The following is a description of a gene set: from publication Amit I, Garber M, Chevrier N, Leite AP, Donner Y, Eisenhaure T, Guttman M, Grenier JK, Li W, Zuk O, Schubert LA, Birditt B, Shay T, Goren A, Zhang X, Smith Z, Deering R, McDonald RC, Cabili M, Bernstein BE, Rinn JL, Meissner A, Root DE, Hacohen N, Regev A (PMID 19729616) Human Gene Set: GSE17721_CTRL_VS_LPS_1H_BMDC_DN Genes down-regulated in comparison of control dendritic cells (DC) at 1 h versus those stimulated with LPS (TLR4 agonist) at 1 h. species: Homo sapiens mouse primary BMDCs were stimulated with tlr ligands and gene expression changes were profiled on Affymetrix arrays, and this is the list of marker genes: ICAM4, HPS4, PROCR (NCBI Gene Id 10544), HCN2, PDPK1, IER3, USH1C, PUM3, TGM2, NFE2L2, PTN, C9orf72, PIWIL1, ID2, TXK, SERPINB2, EEF1B2, NKD1, NINJ2, F2RL3, PPP1R2P1, CYP26A1, HCRT, PGF, CPSF4L, GALK2, RIN2, DRD2, BHLHE41, RAI14, FSTL1, VDAC3, ASB16, SLC4A5, CITED2, CCNG1, FBLN5, FLT3LG, SH3BGRL, MRPL51, CCN1, IFNB1 (NCBI Gene Id 3456), AQP4, RIPK2, PA2G4, FLNB, B3GNT2, PCSK4, CDKN1A, CBR1 (carbonyl reductase 1), INHBA, TPST1, DNASE2B, SYCP3, EHD1, ACAD9, CWH43, LUZP1, CR2, EREG, CHORDC1, DDX10, DDX6, HSPA5, IL23A, GJB1, MYBPH, NDUFAB1, CCNL1, OSR1, IRS2, RANBP10, PRMT3, XPNPEP2, DSCAM, RIPK4, FMO4, ICAM1, TJP2, RAG1, NABP1, MITD1, PCDHB5, ZNRF1 (NCBI Gene Id 84937), TM4SF4, DLD, B3GAT1, HILPDA, ATF7, CHIC2, FTSJ1, USP3, DNAJB9, GDF2, PHOX2A, GSTM1, PPP1R15A, EFNB2, GABPB1, TMEM33, DNAJB4, AKR1A1, TNFAIP2, MEFV, IER2 (NCBI Gene Id 9592), SAA4, TSC22D1, KRTAP13-2, PROM2 (prominin 2), OASL, RDH14, PIBF1, COL12A1, DUSP2, JUN, CCR1, TRPC7, CALB1, PTGER4, NRBF2, MRPL45, TAGLN, SBF2, BRWD3, CPLX3, ADGRG1, SPECC1, CFLAR, NR4A1, MEOX1, CCR6, ABHD1, UPB1, PIP4K2A, BTG3, ATF3, FPR1, EDNRA, UBL7, BLMH, ARID5B (AT-rich interaction domain 5B), THOC1, RWDD4, PDCD1LG2, FAM241B, PAK1IP1, EBI3, ENO3, SPICE1, DPM1, TOR2A, PTX3, MICAL2 (microtubule associated monooxygenase, calponin and LIM domain containing 2), KIF13A, SEMA4F, MTPN, MRC2, MTMR10, NOC2L, FLYWCH2, WNT10B, ERRFI1, CLEC4E, ARHGAP21, PIMREG, CCDC71L, OSBPL1A, TNP1, ZC3H12C (NCBI Gene Id 85463), PLSCR1, KIF17, ZC3H12A, KCNJ9, EPHA3, MAFF, ASB13, ZNF131, UFSP2, ZFP36, TIPARP, IGSF6, CCL13, FAM81A, THOC7, CLCN1, RABEPK, RND3, CLVS1, MAP3K8, B3GNTL1, ALDOAP2, CEMIP, PBDC1, LLGL2, SERPING1, FOS, SIX1, SOWAHC, MST1R